The following is a description of a gene set: The volume enclosed by the dense core granule membrane. Mouse Gene Set: GOCC_DENSE_CORE_GRANULE_LUMEN studied in species Mus musculus, and this is the list of marker genes: Crh, Vps13a, Adcyap1 (adenylate cyclase activating polypeptide 1), Igf1, Ghrl, Penk, Pdyn, Hcrt